The following is a description of a gene set: Human Gene Set: MIR378J Genes predicted to be targets of miRBase v22 microRNA hsa-miR-378j in miRDB v6.0 with MirTarget v4 prediction scores > 80 (high confidence targets). from publication Chen Y, Wang X (PMID 31504780) species: Homo sapiens, and this is the list of marker genes: POC1B-GALNT4, GPATCH11, ZNF664, STN1, RUVBL1, TMEM255A, DYNC1LI2 (NCBI Gene Id 1783), TMX4, FEZF2, GCOM1, TDG, ARHGAP28, NCK1, MYOC, UNC5B, PALS1, SLC26A9, SAMD12, EMC7, MYB, CD1E, AZIN1, ARFGEF3, APOLD1, FUT1, STAG2, ONECUT2, DNMT3A, ZNF534, NAA25, PLS1, CTDSPL, SDHA, FABP2, CERKL, GUCA1C, ZBTB41, FBXL17, MID1IP1, RASAL2, GPR107, CYB5R2, IFT70A, ZMYND8, SYF2, MIER3, USP6NL, FKTN, CCNE2, FER (NCBI Gene Id 2241), DACT1, TMEM199, SMAD4, KCNK1, ESRRG, COLGALT2, RBL2, RAB11FIP2, TK2, RAB27A, OTUD1, MAPK6, TMEM135, DNAJA2, TMEM70, CD164, BICD2 (BICD cargo adaptor 2), SYTL5, MAP3K3, WDR26, ABITRAM, USP14, MMD2, GALNT15, VEGFA, OSTC, GALNT4, TRABD2B, CAND1, FRG2